Given this list of marker genes Ormdl3, Tnf, Atg7, Ccn1, Sirt3, Eed, Nsmaf, Sphk2, Smpd3, Zfp750, Tnfrsf1a, Sphk1, Ormdl2, Samd8, Rack1, Prkcd, Abca2, Enpp7, Pla2g6, Ormdl1, Paqr4, here is a description of the gene set: species: Mus musculus Any process that modulates the frequency, rate or extent of membrane lipid metabolic process. Mouse Gene Set: GOBP_REGULATION_OF_MEMBRANE_LIPID_METABOLIC_PROCESS